The following is a description of a gene set: Mouse Gene Set: CUI_MAST_CELL_IL17E_RESPONSE_UP from publication Cui A, Huang T, Li S, Ma A, Pérez JL, Sander C, Keskin DB, Wu CJ, Fraenkel E, Hacohen N (PMID 38057668) Genes positively differentially expressed in cell type: Mast cell upon treatment with cytokine: IL-17E in mouse lymph nodes in vivo. Cytokines mediate cell-cell communication in the immune system and represent important therapeutic targets. A myriad of studies have highlighted their central role in immune function, yet we lack a global view of the cellular responses of each immune cell type to each cytokine. To address this gap, the authors created the Immune Dictionary, a compendium of single-cell transcriptomic profiles of more than 17 immune cell types in response to each of 86 cytokines (>1,400 cytokine-cell type combinations) in mouse lymph nodes in vivo. A cytokine-centric view of the dictionary revealed that most cytokines induce highly cell-type-specific responses. For example, the inflammatory cytokine interleukin-1β induces distinct gene programmes in almost every cell type. A cell-type-centric view of the dictionary identified more than 66 cytokine-driven cellular polarization states across immune cell types, including previously uncharacterized states such as an interleukin-18-induced polyfunctional natural killer cell state. species: Mus musculus, and this is the list of marker genes: Blcap, Ap2a1, Dubr, Atosa, Eif2b1, Klhl28, Plpp5 (phospholipid phosphatase 5), Gba2, Rfx1, Strip1, Kdelr1, Mink1, Cyp4v3, Parp10, Syt11, Lrch1, Zfp113, Snapc2, Golph3l, Pilrb1, Id1, Nat10, Ccdc88b, Mon1a (MON1 homolog A, secretory traffciking associated), Jpx, Fblim1, Bcorl1